The following is a description of a gene set: from publication Chen Y, Wang X (PMID 31504780) species: Mus musculus Mouse Gene Set: MIR_5046 Genes predicted to be targets of miRBase v22 microRNA mmu_miR_5046 in miRDB v6.0 with MirTarget v4 prediction scores > 80 (high confidence targets)., and this is the list of marker genes: Tfrc, Nrep, Stx1b, Lrrfip1, Akap12, Igf2, H1f0, Eng